The following is a description of a gene set: The transcription factor FoxP3 partakes dominantly in the specification and function of FoxP3+ CD4+ T regulatory cells (Tregs), but is neither strictly necessary nor sufficient to determine the characteristic Treg transcriptional signature. Computational network inference and experimental testing assessed the contribution of several other transcription factors (TFs). Enforced expression of Helios or Xbp1 elicited specific signatures, but Eos, Irf4, Satb1, Lef1 and Gata1 elicited exactly the same outcome, synergizing with FoxP3 to activate most of the Treg signature, including key TFs, and enhancing FoxP3 occupancy at its genomic targets. Conversely, the Treg signature was robust to inactivation of any single cofactor. A redundant genetic switch thus locks-in the Treg phenotype, a model which accounts for several aspects of Treg physiology, differentiation and stability. Human Gene Set: GSE40274_CTRL_VS_FOXP3_AND_PBX1_TRANSDUCED_ACTIVATED_CD4_TCELL_DN studied in species Homo sapiens Genes down-regulated in CD4 T conv: control versus over-expression of PBX1 and FOXP3. from publication Fu W, Ergun A, Lu T, Hill JA, Haxhinasto S, Fassett MS, Gazit R, Adoro S, Glimcher L, Chan S, Kastner P, Rossi D, Collins JJ, Mathis D, Benoist C (PMID 22961053), and this is the list of marker genes: C8orf33, RAP2B, FOXO6, FGF11, TMEM200B, PLEKHG4, HSPD1, CSRP1, KRT23, CCR6, PSMB3, WDR19, ATP5MF, RRP36, IFNG, LAS1L, TICAM2, MSTO1, FAM53B, MAB21L1, EFNA2, MC2R, ADAMTS15, OLFML2B (NCBI Gene Id 25903), NAMPT, NOL4, NAA38, EIF3K, PRDX1, LCMT1, RBM38, HSP90AB1, NRG1, TAF9, LRRC58, TACC2, SLC25A39, LRP11 (LDL receptor related protein 11), DENR, RXRG, EEF2, C3orf52, KRTCAP3, PHYHIP, UFC1, E2F1, IMPDH2, HOMER1, EXOC3, TIMM50, PTK6, HMGN1, ST6GALNAC6, RBPJ, CHMP2B, B4GALNT1, SRP9, ERGIC1, H1-6 (NCBI Gene Id 3010), HAL, EIF1AX, BMI1, IRX6, WNT10B, OXCT1, FRZB, TGIF2, EDF1 (endothelial differentiation related factor 1), AXDND1, AIFM1, SOD2, LYPLA2, MIRLET7E, MCM6, CSF1, LMNB2 (NCBI Gene Id 84823), TMEM121B, ZFAND5, PLIN3, ADAM2, TULP2, REM2, QSOX1, ABHD6, XXYLT1, IRF4 (interferon regulatory factor 4), PSMA6 (proteasome 20S subunit alpha 6), LRRC9, TIPIN, BRI3, PIP5K1C, PKM, EIF3M, CXXC4, HMOX1, TLR2, P3H1, DCTPP1, ACTL10 (NCBI Gene Id 170487), MYBL1, BAIAP2, PIGR, GRIA4 (NCBI Gene Id 2893, glutamate ionotropic receptor AMPA type subunit 4), PSMB5, BATF, HAUS1 (HAUS augmin like complex subunit 1), NT5C1B, UNG, NFE2L1, RBM17, SNORD52, SRA1, IDE, HRAS, METTL16, GSTM2 (NCBI Gene Id 82152), TENT5C, ETFA, NCAM2, MAGOH, ACACA, BMP3, ILF3, EIF3C, ASIC3, CRISP3, CHCHD6, PLK3, LIG1, BEX3, ASL, EFHD2, SHMT1, NDUFA1, MIR125A, CLPP, TGFB3, EIF3E, NRP2, CNIH2, ERH, KRTDAP, NDUFA3, ECEL1, WDR43, FOXRED2, SYT14, VAT1, SDC1, MELK, CSRP2, CALM1, PSMC3IP, FUNDC2, MCRS1, DYTN, SPEF2, TOMM22, CITED1, EMC8, CPD, PCGF5, LRRC10B, RFWD3 (NCBI Gene Id 55159)